Given this list of marker genes EIF4A3, TBX15, NEK1, FLNA, ZSWIM6, GLI3, here is a description of the gene set: Shortening of the middle parts of the leg in relation to the upper and terminal segments. species: Homo sapiens Human Gene Set: HP_MESOMELIC_LEG_SHORTENING Mesomelic leg shortening